The following is a description of a gene set: The process of creating protein oligomers, compounds composed of a small number, usually between three and ten, of component monomers; protein oligomers may be composed of different or identical monomers. Oligomers may be formed by the polymerization of a number of monomers or the depolymerization of a large protein polymer. studied in species Homo sapiens Human Gene Set: GOBP_PROTEIN_COMPLEX_OLIGOMERIZATION, and this is the list of marker genes: KCTD8, C9, KCNB1 (NCBI Gene Id 3745), TRIM72, KCND1 (potassium voltage-gated channel subfamily D member 1), OXA1L, HDAC6, MICU1, TIFA, TRPM7, RYR3, PKD2L1, KCTD7, OTOL1, CALHM1, AQP11 (NCBI Gene Id 282679), BLM, HSD17B10, CALHM3, ITPR1, KCTD6, KCNA1, COMP, SPAST, KCNN4, SYCP1, PDCD6IP, STK4, KCTD21, ALDH1A3, RNF135, HOMER1, TRPM3 (NCBI Gene Id 80036), NUDT21, MOSPD2 (NCBI Gene Id 158747), TWNK, NACC2, TMEM120A, RBMX, PKD2, CUTC, ELAVL1, IAPP (NCBI Gene Id 3375), KCNG4, HLA-DRB1, VWA1, MAT2A, SLC9A1, NLRP1 (NCBI Gene Id 82286), FARSA, PYCARD, CLYBL, BCL10, HGSNAT, FKRP, TP63, EP300, KCTD13, SYT1, GLRA3, TRPM2, SSBP1, KCNS3, JMJD6, KCNV2, GRIA3, TRPV5, KCNF1, PRNP, ITLN1, ALS2, KCTD17, KCTD4, APIP, KRT1, RS1, HLA-G, SAMHD1, GRIN1, AQP5, KCNA2, TP73, RIPK2, ACACA, KCTD12, VPS35, KCTD5, MIF, EHD1, HCN1, SAMD1, IFIH1, CTH, PRMT1 (NCBI Gene Id 3276), BASP1, SHKBP1, CRTC3, ZNHIT6, TP53, TDO2, KCNJ2, KCNA10, KCNRG, SCARA5, USP16, MPP2, YME1L1, AQP2, CPSF6, RNF112, BEST1, SIGMAR1, GRIN2B, RRM2, OAS1, SHMT2, THG1L, LETM1, OPA1, PXDN, ECT2, NLRC4, ARC, MLKL (NCBI Gene Id 197259), MCU, PRPH2, PRMT8 (protein arginine methyltransferase 8), AQP4, STEAP4, KCTD15, TP53BP1, SNCA, GLS, ZC3H12A, KCNG2, KCNT1, FUS, GNMT, WDCP, MS4A1, CD247 (NCBI Gene Id 919), SLC31A1, EHD3, KCTD18, CBY1, ISG15, UPB1, KCTD19, ARHGAP27, G3BP2, SNUPN, CEP57, APP, KCND2, NLRP6, ABCA3, DEFA5, KCNC2, CHMP2A, IKZF4, HPRT1, LRRC8C, MAPT, ATL1, LRRC8A, KCNA6, OSBPL2, ALDH1A2, GBP5, GOLGA2, ZNF777, TMEM70, KCNC1, KCNV1, EHD4, CBR4 (carbonyl reductase 4), ATL3, TK1, KCNA5, APPL2, KCNG3, STK3, TRPA1, SLC1A5, ACOT13, CD2AP, TNFAIP1, KCTD16, DNM1, KCTD9, TRPM1, PKD1, HSD17B8, KIF25, KCNB2, ITPR3, KCNA7, ATL2, SLC1A2, KCNA4, KCNC3, COL6A1, CRTC1, TMEM120B, TRPM6, COL1A2, CARD9, VASP, PNPT1, PEX5, KCNG1, KCNS1, DNM1L, BCL11A, B2M, CD74, ACACB, KCND3, KCTD1, ADCY8, CRTC2, FARSB, BOK, KCTD10, MAT1A, NINJ1, TRPV1, ZNF746, NOL3, CARD11, RYR1, ALDOA, EVL, GSDMD, SHMT1, KRT10, BEND3, PRND (NCBI Gene Id 23627), KCNS2, TGM2, ALOX5AP, POLQ, PRF1 (perforin 1), UGDH, SGTB, KCNA3, NLRP3, ME1, KCNJ12, VSTM5, DELE1, KCTD11, LRRC8D, RRM1, ROM1, STING1, ZBTB1, CARD8, KCNC4, P2RX3, AQP10, CRYZ, ALAD, CLDN1, KCTD14, KCTD3, ALDH9A1, TRIM65 (NCBI Gene Id 201292), PEG10 (paternally expressed 10), TRPM4, HSCB, P2RX7, MCOLN1, CPSF7, SOD2 (superoxide dismutase 2), KCTD2, STOML2